Given this list of marker genes SOS1, UBA52, RPS27A, EGF, HSP90AA1, CDC37, PIK3CA, GRB2, SHC1, CBL, PLCG1, HRAS, UBC, PIK3R1, NRAS, GAB1, EGFR, UBB, KRAS, here is a description of the gene set: studied in species Homo sapiens Human Gene Set: REACTOME_CONSTITUTIVE_SIGNALING_BY_LIGAND_RESPONSIVE_EGFR_CANCER_VARIANTS Constitutive Signaling by Ligand-Responsive EGFR Cancer Variants